The following is a description of a gene set: Human Gene Set: REACTOME_DISORDERS_OF_TRANSMEMBRANE_TRANSPORTERS Disorders of transmembrane transporters studied in species Homo sapiens, and this is the list of marker genes: ABCB11, NUP54, NUP85, SLC24A4, PSMC3, NUP214, AVPR1B, ABCD4, NUP153, PSMB6, SLC34A3, UBA52, NUP35, SLC39A4, SLC34A1, POM121, PSMD6, SLC16A1 (solute carrier family 16 member 1), PSMA2, SLC27A4, NUP107, GCK, SLC6A5, SLC2A2, BSG, POM121C, PSMD2, NUP210, SLC5A2, SLC36A2, SLC17A5, ABCC9, NUP98, ERLEC1, NUP50, SLC4A4, OS9, ABCG5, PSMA4, NUP133, ABCD1, SLC3A1, RPS27A, SLCO1B1, AAAS, SLC7A7, RHAG, NUP58, SLC6A3, RAE1, PSMB1, ABCA3, DERL3, SLC26A2, SLC6A19, SLC33A1, PSMD14, LMBRD1, SLC6A20, CFTR, SLC2A1, SLC5A5, SLC35A1, SLC17A8, AVPR1A, SEM1, SLC9A6, RNF185, TPR, PSMA3, PSMC1, PSMD8, NDC1, RNF5, DERL1, SLC20A2, SLC29A3, PSMD3, SLC22A18, NUP42, ABCB6, SLC24A5, ABCG8, PSMD1, ABCA12, HK1, SEC13, GCKR, PSMC2, SLC1A1, SLC35A3, SEL1L, PSMA1, SLC34A2, HEPH, SLCO2A1, NUP93, ABCC2, SLC1A3, NUP43, ERLIN1, SLC3A2, SLCO1B3, SLC24A1, PSMC4, SLC2A10, PSMA7, SLC35C1, SLC35A2, ABCA1, PSMB7, SEH1L, PSMD13, PSMD11, PSMC6, PSMD12 (NCBI Gene Id 5718), ABCC8, SLC22A12, SLC9A9, PSMD7, ABCB4, AVPR2, SLC12A6, SLC2A9, PSMB3, SLC40A1, UBC, NUP188, DERL2 (derlin 2), SLC6A18, PSMC5, SLC22A5, ADRM1, PSMA6, SLC12A3, SLC5A7, NUP62, NUP205, SLC7A9, SLC4A1, PSMB2, SLC26A4, NUP37, SLC6A14 (NCBI Gene Id 282807, solute carrier family 6 member 14), SLC12A1, ABCC6, KCNJ11, SLC6A2, PSMB4, VCP (NCBI Gene Id 94731), UBB, SLC11A2, NUP160, NUP88, NUP155, CP, PSMB5, ERLIN2, SLC26A3, PSMA5, APOA1, RANBP2, AVP, SLC5A1